The following is a description of a gene set: studied in species Homo sapiens from publication Beier UH, Wang L, Han R, Akimova T, Liu Y, Hancock WW (PMID 22715468) Genes up-regulated in T reg: wildtype versus HDAC9 knockout. Human Gene Set: GSE36095_WT_VS_HDAC9_KO_TREG_UP Targeting histone/protein deacetylase (HDAC)-6, -9, or Sirtuin-1 (Sirt1) augments the suppressive functions of Foxp3+ T regulatory (Treg) cells, but it is unclear if this involves different mechanisms, such that combined inhibition would be beneficial. We compared the suppressive functions of Tregs from wild-type C57BL/6 mice or mice with global (HDAC6-/-, HDAC9-/-, dual HDAC6/9-/-) or conditional deletion (CD4-Cre or Foxp3-Cre and floxed Sirt1; GSE26425) alone, or after treatment with isoform-selective HDAC inhibitors (HDACi). We found the heat shock response was crucial in mediating the effects of HDAC6, but not Sirt1 inhibition. Furthermore, while HDAC6, HDAC9 and Sirt1 all deacetylate Foxp3, each has diverse effects on Foxp3 transcription, and loss of HDAC9 is associated with stabilization of Stat5 acetylation and its transcriptional activity. Targeting different HDAC can increase Treg function by multiple and additive mechanisms, indicating the therapeutic potential for combinations of HDACi in the management of autoimmunity and alloresponses post-transplant., and this is the list of marker genes: GSTO1, NUDT22, MAP2K1, USP10, MIR367, GLUL, RASGRP3, ACAA2, WDFY4, ECT2, DDX19A, NFKBIZ (NFKB inhibitor zeta), SLC52A1, PREB, TPD52, KIF23, TXNIP, CTNNA1, CD24, ARMCX3, MMD, CYFIP1, UNC93B1, IFI30, PFKL, PROS1, BLTP3B, SEMA7A, TGFA, FCRL1, PGAP2, CEP55, PPFIBP1 (NCBI Gene Id 8496), FAM78B, RPIA, KCNQ5, ASPM, PRC1, CHST15, UBAC2, ACSBG1, OTULIN, CDKN1A, AKAP7, NFKB1, RAPH1, HSPBAP1, MFF (NCBI Gene Id 56947), TMEM107, TNFAIP8, MEF2C, ADCY6, VIL1, PANX1, NEDD1, BLK, PRKCSH, EYA2, HAUS4, IPO5, MTMR14, PLXDC2 (plexin domain containing 2), SLC27A2, ADAMTS6, TNFAIP3, HYCC1, GSTT2, TDP1, TUBA1A, S100A6, RFWD3, MYO1E, OPA1, KIF20B, TMEM35A, KIF11, SAMSN1, CLPTM1, GOT1, PLCG2, BLNK, ALKBH6 (NCBI Gene Id 84964), XBP1, DGAT1, NFKBIA, PDE1B (NCBI Gene Id 5153), YEATS4, MASTL, PPP2R3A, WEE1, MPDU1, PLK1, NUF2, SNX9, SLC43A1, DUSP6, PPARG, PDE7A, RHOB, VAV2, CHAF1B (chromatin assembly factor 1 subunit B), ANXA4, CTSH, ELL2, H3-3B, RNF41, CYBB, SCD, ASF1B, PIM1, PLIN2, BANF1, FNDC8, PLCXD2, NIT2, NAPSA, RAB11FIP2, GZMB, SLC43A3, CASP8, TIA1, NMRK2 (NCBI Gene Id 27231), APOE, SIRT4, PHLDA1, HIF1A, BZW2, AAAS, FBXW8, ETFB, CR2, SPRR4, DNAJB13, IRF5, CD19, MS4A1, TRABD, RAPGEF5, TBCB, TMPRSS13, ESCO2, JMJD1C, CD36, HDAC1 (histone deacetylase 1), BCAT1, CISH, SQLE, ALDOC, USP18, MR1, CD22, KHDRBS3, ARHGEF3, LDHA, USF1, LIF, CDC42SE2, LRRC57, CD2, GZF1, NBAS, TOM1, SLC23A2, LPCAT3, SYPL1, SERPINE2, PLK2, CFAP144P1, HMGN3, FAM114A2, USP54, SPATA13, STIL, CENPI, MXD4, PLA2G4F, CERK, CTSZ, IMPA2, MPZL2, PA2G4, GTF2IRD2